The following is a description of a gene set: FGFR2 amplifications have been identified in 10% of gastric cancers, where they are associated with poor prognosis diffuse cancers, and in ~1% of breast cancers. FGFR2 amplification often occur in conjunction with deletions of C-terminal exons, resulting in expression of a internalization- and degradation-resistant form of the receptor. Amplification affects signaling without altering the intrinsic kinase activity of the receptor. Signaling through overexpressed FGFR2 also shows evidence of being ligand-independent and sensitive to FGFR inhibitors. part of: FGFR2 mutant receptor activation Reactome Pathway: Signaling by FGFR2 amplification mutants species: Homo sapiens, and this is the list of marker genes: FGFR2